Given this list of marker genes CPSF6 (NCBI Gene Id 11052), BCL11B, BRPF3, SCN2B, TSPY3, SEMA5B, ZC3H12C, INTS6L, RBBP4, ZKSCAN5, GOLGA4, STK38L, STOX2, ZNF154, GFM1 (NCBI Gene Id 85476), CACNA1H, CRCP, KDM6A, PRKCI, ITGA6, CEP72, ERCC6L2, MIB1, PLEKHF2, MBTD1, CXXC4, ZNF280B (NCBI Gene Id 23748), TSPY2 (testis specific protein Y-linked 2), FEZF2, NEDD9, TSPY10, RFX7, SEC22B, RAPH1, UBE2V2, TENT5C, TNFAIP1, HSPA4L, MAP3K1, TOX3, CPEB3, SIX4, GPR158, GABARAP, PDCD6IP, DHX38 (DEAH-box helicase 38), NR2E1, NFATC3, ALAD, SLC24A2, ABRAXAS2, TTC19, DENND1B, NEFL, AMMECR1, LHFPL3, FCHO2, KCNMB2, ZSWIM2, REEP3, EDEM3, ZPLD1, OPCML, PLAT, EIF4A1, EIF3L, ZZEF1, KDM5B, PRPS2, PPFIBP1, VGLL3, PIP4P2 (phosphatidylinositol-4,5-bisphosphate 4-phosphatase 2), BNC1, TSPY8, GPR161, TOB2, LRRTM1, CYP11B1, LSAMP, ANKS1A (NCBI Gene Id 23294), C22orf23, CDH5, UBXN1, NOD2, UBN2, LCOR, PAH, TNPO1, CABP5, SSBP2, PPP2R5E, SH2B3, WHAMM, KCMF1, ITCH, ERMAP, SGPP1, EVI2B, TRERF1, PPBP, HRH2, EGR1, TSPY4, ANKRD12, TWIST2, TSPY1, COG6 (component of oligomeric golgi complex 6), ASB5, BICD2, PTBP3, TMEM170B, TNFSF14, LCMT2, CLOCK, SCN2A, ZNF546, FRYL, MKNK1, TRIO, MARS2, ZNF223, AGFG1, CDH10, GHSR, STK31, MYOC (NCBI Gene Id 4653), ATPAF1, KIRREL1, C1orf52, NCAM1, SINHCAF, CRK, AMBN, CNOT7, NRBP1, PLTP, KLF4, TENM1, TSPAN9, here is a description of the gene set: from publication Chen Y, Wang X (PMID 31504780) Human Gene Set: MIR3140_5P Genes predicted to be targets of miRBase v22 microRNA hsa-miR-3140-5p in miRDB v6.0 with MirTarget v4 prediction scores > 80 (high confidence targets). species: Homo sapiens